The following is a description of a gene set: NRIF (nuclear receptor-interacting factor) is a DNA binding protein that is essential for p75-mediated apoptosis in retina and sympathetic neurons. Neurotrophin or proneurotrophin binding to p75TR induces nuclear translocation of NRIF, which involves gamma-secretase cleavage of p75NTR ICD (Intra Cellular Domain). Once in the nucleus, NRIF mediates apoptosis, probably by acting as transcription factor. part of: Cell death signalling via NRAGE, NRIF and NADE Reactome Pathway: NRIF signals cell death from the nucleus studied in species Homo sapiens, and this is the list of marker genes: NGF, APH1A (NCBI Gene Id 82089), SQSTM1, RPS27A, APH1B, UBB, UBC, TRAF6, PSEN1, UBA52, ITGB3BP (NCBI Gene Id 23421), PSENEN, PSEN2, NGFR, MAPK8, NCSTN